Given this list of marker genes LRCH4, ITGAL, MSL1, FLI1, TRIM22, TSC22D3, GIMAP6, SIPA1, STK38, SEMA4D, CASP8, ZNF394 (NCBI Gene Id 84124), CORO1A, CD53, KDM5A, RIPOR2, PARP12, OSTF1, LCP2, HLA-F, PTPRC, FYB1, RNF44, PARP8, PTPN6, TUT7, FMNL1, WIPF1, SNX6, TXNIP, ARHGAP4, IL10RA, RIN3, DDX5, CD48, GSAP (NCBI Gene Id 54103), CYTH1, HLA-A, GRK6, TRAF3IP3, HLA-G, SNRK, HLA-C, ADGRE5, KLF2, VAV1, ARHGAP45, MBNL1 (muscleblind like splicing regulator 1), ADAM8, ICAM3, BIN2, RAP1B, HECA, STK10, JAK1, HLA-E, ADCY7, CYTIP, HLA-B, PSTPIP1, HCLS1, GPR65, C11orf21, CLEC2B, PHF11, BTN3A3, WAS, RAC2, here is a description of the gene set: species: Homo sapiens Human Gene Set: GNF2_PTPRC Neighborhood of PTPRC Neighborhood of PTPRC protein tyrosine phosphatase, receptor type, C in the GNF2 expression compendium